Given this list of marker genes NEDD4L, MECP2, DHX30, NSRP1, CRELD1, DLAT, CAMK2B, SUCLG1, EN1, SPTBN1, GEMIN4, FARSB (phenylalanyl-tRNA synthetase subunit beta), LINS1, ITPR1, COX10, MPZ, LYRM4, TIMM50, UBA1, MICOS13, SERPINH1, MMAB, CDK5, SLC25A12, NAA20, MYL1, NONO, SLC31A1, RNH1, LAMB2, IFT140, UGP2, here is a description of the gene set: The Premie-Neuro and the Dubowitz Neurological Examination score head lag in the same manner. Scoring for both is as follows: 0 = head drops and stays back, 1 = tries to lift head but drops it back, 2 = able to lift head slightly, 3 = lifts head in line with body, and 4 = head in front of body. This term applies if head lag persists beyond an expected age at a level of 0 or 1. Persistent head lag beyond age 4 mo has been linked to poor outcomes. Human Gene Set: HP_PERSISTENT_HEAD_LAG Persistent head lag studied in species Homo sapiens